Given this list of marker genes Gm14391, Esrrg, Igf2, Nsd3, Gon7, Rbm18, Cadm1, Trim33, Cdc27, Rspo2, Shoc2, Lpar4, Yaf2, Cd38, Lin7c, Kpnb1, Ddx3x, Psmc6, Trpc5, Tent5a, Sp4, Fmr1, Fgfr1op2, Pdss1, Slc35f6, Zfp608, Agfg1, Casd1 (NCBI Gene Id 213819), Gabrb2, Amfr, Ccdc60 (NCBI Gene Id 269693), Rtl4, Zeb2, Fzd4, Dcx (NCBI Gene Id 13193), Mylk, Tox, Tob1, Pcnt, Per3, Khdc1a, Ftsj1, Tshz3, Magohb, Tmtc2, Nmnat3, Zc3h12c, Bdnf, Wipf3, Zbtb41, Txnl1, Fancm, Esp36, Polr2c, Dnm3, Kdelr2, Zfp93, 1600012H06Rik, Lingo2, Rgs7, Nfkbiz, Stk11, here is a description of the gene set: Genes predicted to be targets of miRBase v22 microRNA mmu_miR_192_3p in miRDB v6.0 with MirTarget v4 prediction scores > 80 (high confidence targets). Mouse Gene Set: MIR_192_3P studied in species Mus musculus from publication Chen Y, Wang X (PMID 31504780)